The following is a description of a gene set: Human Gene Set: BROWNE_INTERFERON_RESPONSIVE_GENES studied in species Homo sapiens The effect of human cytomegalovirus (HCMV) infection on cellular mRNA accumulation was analyzed by gene chip technology. During a 48-h time course after infection of human diploid fibroblasts, 1,425 cellular mRNAs were found to be up-regulated or down-regulated by threefold or greater in at least two consecutive time points. Several classes of genes were prominently affected, including interferon response genes, cell cycle regulators, apoptosis regulators, inflammatory pathway genes, and immune regulators. The number of mRNAs that were up-regulated or down-regulated were roughly equal over the complete time course. However, for the first 8 h after infection, the number of up-regulated mRNAs was significantly less than the number of down-regulated mRNAs. By analyzing the mRNA expression profile of cells infected in the presence of cycloheximide, it was found that a minimum of 25 mRNAs were modulated by HCMV in the absence of protein synthesis. These included mRNAs encoded by a small number of interferon-responsive genes, as well as beta interferon itself. Cellular mRNA levels in cytomegalovirus-infected cells were compared to the levels in cells infected with UV-inactivated virus. The inactivated virus caused the up-regulation of a much greater number of mRNAs, many of which encoded proteins with antiviral roles, such as interferon-responsive genes and proinflammatory cytokines. These data argue that one or more newly synthesized viral gene products block the induction of antiviral pathways that are triggered by HCMV binding and entry. from publication Browne EP, Wing B, Coleman D, Shenk T (PMID 11711622) Genes up-regulated in primary fibroblast culture after treatment with interferon alpha for 6 h., and this is the list of marker genes: IFI44L, SAMHD1, THEMIS2, STX11, TYMP, UBE2L6, IFIT2 (interferon induced protein with tetratricopeptide repeats 2), WARS1, IFI27, TRIM14, CCL8, IL15, BAZ1A, PSMB9, TRIM21, HLA-F, ISG15, CXCL10, TRIM22, PML, TAP1, SP110, GMPR, IFI35, PLAAT4, GCH1, RSAD2, IDO1, PDZD2, RBCK1, RABGAP1L, GBP2, OASL, KIF5C, LMO2, SP100, TREX1, NMI, ZBTB20, OAS2, TDRD7, APOBEC3G, IFI44, MX2, IFIT5, PSMB8, ISG20, MELK, CYTH1, MYD88, STAT1, OAS1, TNFSF10, PLSCR1, CASP1, XAF1, EIF2AK2, RGL1, IFI6, IL15RA (interleukin 15 receptor subunit alpha), GBP1, IRF7 (interferon regulatory factor 7), BST2, TLR3, IFIT3, MX1, IFI30